The following is a description of a gene set: species: Homo sapiens Genes down-regulated in comparison of healthy myeloid cells versus systemic lupus erythematosus myeloid cells. Gene expression profile studies have identified an interferon signature in whole blood or mononuclear cell samples from patients with systemic lupus erythematosus. This study was designed to determine whether specific lymphocyte and myeloid subsets freshly isolated from the blood of systemic lupus erythematosus patients demonstrated unique gene expression profiles compared to subsets isolated from healthy controls. Human Gene Set: GSE10325_MYELOID_VS_LUPUS_MYELOID_DN from publication Hutcheson J, Scatizzi JC, Siddiqui AM, Haines GK 3rd, Wu T, Li QZ, Davis LS, Mohan C, Perlman H (PMID 18275831), and this is the list of marker genes: SRP54 (signal recognition particle 54), SPTLC2, NMI, MCUB, WWC3, IGSF6, ATOX1, SIGLEC1, PEF1, SLC2A3, TRANK1, PDSS1, CEMIP2, DESI1, IFI27, PROSER1 (NCBI Gene Id 80209), SLC39A8, ADAM17, LAP3, MT1H, PSMF1, PANX1, SNTB1, TMEM255A, ISG15, LSM12, XBP1, F5, ZNF410, SLC16A6, MARCO, IL15RA, TMEM185B, EHD4, IFI6, SERPING1, PSMA6, HLA-A, ADAR, LAIR1, UPP1 (NCBI Gene Id 7378), IGF2R, DDX60, C1QB, CUL1, KLF9, GIMAP4, DRAP1, GM2A, POMP, LAMP1 (lysosomal associated membrane protein 1), CASP7, FCGR1BP, KDELR1, TOP1, PIM1, TOR1A, IFIT1, TOR1B, SP100, ADO, DDA1, PLIN3, ATG7, EPB41L3, PDPN, MAIP1, EIF2AK2, CXCL10, XAF1, FAM168A, SRSF9, ERO1A, MT1X, HLX, ACSL1, MX2, TNS1, LDLR, CCL8, IFIT3, GK, USP18, SHC1, IFI35, SPATS2L, AQP9, NRAS, TNFAIP6, CD63, CHST11, IFIH1, IRF7, MAPK1IP1L, PLIN2 (NCBI Gene Id 123), STAT3, ATP10A, SEC22B, SEMA4D, CDK7, HERC6, MAPK6 (NCBI Gene Id 5597), LGALS3BP, CDS2, NAIP, MILR1, IFI44, DHX8, MT2A, CXCL11, CTBS, FFAR2, LIMK2, GMPR, EDEM2, FOLR3, GNPDA1, NIBAN1 (niban apoptosis regulator 1), POP4, OASL, ATP2A2, ADM, APOL6, ACP2, GLG1, IFI16, KMO, PLEK, HERC5, CDC73, PTP4A1, STAT1, CTSD, TAP1, STEAP4, IL1RN, GTPBP2, TXN, FMNL1 (formin like 1), PSME2, MX1, ZCCHC2, PARP12, IFITM1, QKI, PHACTR2, HPRT1 (NCBI Gene Id 3251), MFSD5, KYNU, MICB, VRK2, GABPA, LY6E, VTI1B, CCL2, JUP, HESX1 (NCBI Gene Id 8820), PKM, GBP1, LGALS9, RTP4, UBE2K, UBE2L6, DPM1, RBCK1, DGUOK, CTSA, RGL1, APOL1, CALM3, EMC7, TFEC, IFIT5, SCO2, TFG, FLVCR2, RAB8B (RAB8B, member RAS oncogene family), SLC25A37, PAFAH1B1, CBR1, MT1F, DHX58, ADPGK, MED8, GK3, GID8, RSAD2 (radical S-adenosyl methionine domain containing 2), GRINA, CALM1, SLC38A2, ABCC10, CRYZL1, LMNB1, NUCB1, MAP7D1 (NCBI Gene Id 55700), PLSCR1, TMSB10, PANK4, RNASEH1, IFIT2